Given this list of marker genes Sh2b2, Tnfaip3, Abl1, Ahr, Enpp1, Hif1a, here is a description of the gene set: Mouse Gene Set: GOBP_B_1_B_CELL_HOMEOSTASIS species: Mus musculus The process of regulating the proliferation and elimination of B cells of the B-1 subset such that the total number of B-1 B cells within a whole or part of an organism is stable over time in the absence of an outside stimulus. B-1 B cells are a distinct subset of B cells characterized as being CD5 positive, found predominantly in the peritoneum, pleural cavities, and spleen, and enriched for self-reactivity.